Given this list of marker genes CTSL, IARS1, UHRF1 (ubiquitin like with PHD and ring finger domains 1), TFRC, NCOA4 (NCBI Gene Id 8031), GAL, RPS2, SELENOP, EIF2A, CNBP, RNF10, FNTA, KHSRP, NUCB2, CKS2, TUBB, DDB1, TXNRD1, RAB5A, ATP5MC3, PCNA, RBX1, CCNA2, LIG4, ABRACL, PNP, NAMPT, EXOSC4, PABPC1P2, MYL6B, ZFP36L1 (ZFP36 ring finger protein like 1), VAV3, PSMA2, here is a description of the gene set: Human Gene Set: CAFFAREL_RESPONSE_TO_THC_24HR_5_UP Genes up-regulated in EVSA-T cells (breast cancer) treated with 5 micromolar THC (delta-9-tetrahydrocannabinol) for 24 h. from publication Caffarel MM, Moreno-Bueno G, Cerutti C, Palacios J, Guzman M, Mechta-Grigoriou F, Sanchez C (PMID 18454173) studied in species Homo sapiens It has been recently shown that cannabinoids, the active components of marijuana and their derivatives, inhibit cell cycle progression of human breast cancer cells. Here we studied the mechanism of Delta(9)-tetrahydrocannabinol (THC) antiproliferative action in these cells, and show that it involves the modulation of JunD, a member of the AP-1 transcription factor family. THC activates JunD both by upregulating gene expression and by translocating the protein to the nuclear compartment, and these events are accompanied by a decrease in cell proliferation. Of interest, neither JunD activation nor proliferation inhibition was observed in human non-tumour mammary epithelial cells exposed to THC. We confirmed the importance of JunD in THC action by RNA interference and genetic ablation. Thus, in both JunD-silenced human breast cancer cells and JunD knockout mice-derived immortalized fibroblasts, the antiproliferative effect exerted by THC was significantly diminished. Gene array and siRNA experiments support that the cyclin-dependent kinase inhibitor p27 and the tumour suppressor gene testin are candidate JunD targets in cannabinoid action. In addition, our data suggest that the stress-regulated protein p8 participates in THC antiproliferative action in a JunD-independent manner. In summary, this is the first report showing not only that cannabinoids regulate JunD but, more generally, that JunD activation reduces the proliferation of cancer cells, which points to a new target to inhibit breast cancer progression.